Given this list of marker genes B230219D22Rik, Igf1, Cntnap2, P2ry10, Aasdhppt, Dlg2, Angptl7, Sgcg, Aplf, Nfia, Ncam2, Cd36, Tfap2a, Elavl4, Blvrb, 1500009L16Rik, Angptl2, Rbm47, Cep135, Gm13889, Vsnl1, Gm14434, Pcdh17, Wbp2, Mrpl3, Rfx1, Tcf12, Ankrd13b, Pde4d, Gm14308, Drd5, 2210418O10Rik, Kpna3, Enpp4, Adarb2, Slc30a1, Zfp970, Zc3h12c, Nrxn1, Lrrc4c, Gm2026, Gm14325, Zc3h12d, Erc1, Gm4724, Zfp971, Birc6, Tbl1xr1, Il22ra1, Tsc22d1, Zfp26, Vgll3, Senp6, Gpr158, Gm6710, Zfp830, Rock1, Prss8, Gngt2, Plcxd2, Dnajb11, Nfasc, Sh3rf2, Hoxa5, Zfp967, Clvs1, Isca1, Aipl1, Gria3 (NCBI Gene Id 73036), Rbms3, Snx27, Arih1, Il12b, Gm14296, Intu, Pggt1b, Zfp966, Fam91a1, Uty, Nr3c2, Ankrd29, Pcdh11x, D130043K22Rik (RIKEN cDNA D130043K22 gene), Gm14322, Cpne4, Zfp185, Slc24a2, Asap1, Adamtsl1, Pde4b, Nkx2-1, Zswim6, Adam25 (NCBI Gene Id 23793), Ctnna2, Psmd12, Zfhx3, Cd8a, Carf, here is a description of the gene set: studied in species Mus musculus Mouse Gene Set: MIR_592_5P from publication Chen Y, Wang X (PMID 31504780) Genes predicted to be targets of miRBase v22 microRNA mmu_miR_592_5p in miRDB v6.0 with MirTarget v4 prediction scores > 80 (high confidence targets).